Given this list of marker genes CXCL11, TRIM31, PELI1, IFIH1, USPL1 (NCBI Gene Id 10208), SLC31A2, HMGN2P46, NACA2, APOBEC3A, H1-6, SYNPR, ARHGAP27, DNAJB5, MYEF2, NR4A3, DNAJC27, RAB11FIP1, CLK4, EPSTI1, SWT1, TENT4A, BPIFA2, PGAP1, GTPBP2, GFOD1 (NCBI Gene Id 96191), SPATA18, PARP6, C1GALT1, PARP14, ADAR, WDR33, OASL (2'-5'-oligoadenylate synthetase like), PATL2, SAMD9, SAP30L-AS1, LINC03007, ADM, IRF7, RNF213, GADD45B, S100A7, HESX1, DAND5, C2orf15 (NCBI Gene Id 150590), UNC93B1, UGT2B15, DHX58, TENT5A, BATF2, IFIT2, TMEM212, CCDC57, MYO10, FBXO34, PATL1, ANKS1B, PLA1A, TLK2, DENND2C, B3GAT2, IFI44, IFIT3, PMAIP1 (NCBI Gene Id 9305), FUT4, CATSPERE, TRIM21, RIGI, IRF1, DTX3L, ZBP1, PML, CLK1 (CDC like kinase 1), SPC24, ZNFX1, SRC, SCN11A, DDIT4, IFIT1, IFI35, SIRPG, STAT2, DOP1A, ARID3A, DRC3, ZBTB43, NAMPT, SLC25A28, TGIF1, MASTL, KIF2A, MX1, REC8, HSPA4L, RNF43, HOMER1, MX2, PARP9, KDM6B, MT2A, TRIM25, SORBS3, B4GALT5, SLC1A6, DCP1A, TRIM56, GCH1, CD274, ISG15, DUSP15, C3orf36, PNPT1, CREB5, DIPK1B, PPM1K, SAMD9L, IFI6, UTY, SNAPC1, USP42, C3orf38, NLRC5, RLF, TTC9B, PROC, CCL8, ARL5B, ERRFI1, XAF1, MVB12A, CD80, PHF11, SETD4, PRX, IFI44L, ZNF687, IRAK2, INKA1, RTP4, MAK, NINJ1, THAP3, TRAF1, DDX60, RICTOR, IFIT5, TMEM217, CARINH, LCAL1, IL36A (NCBI Gene Id 83004), HERC6, PAPOLG, RASAL1, PELO, KPNA5, NDC80, ISG20, TNNT1 (troponin T1, slow skeletal type), TAP1, MYADM, MFN1, PLSCR1, LINC02537, SHFL, OAS3, CXCL10, PPP3CC, SNORD89, DDX60L, FNBP4, NT5C3A, APOL1, IFITM1, USP18, HERC5, SP140L, DUSP5, OAS2, MIS18BP1, RSAD2, NR2E1, HELZ2, CMPK2, TAMALIN, TNFSF10, CSRNP1, NFKB2, ZNF107, ARHGAP8, here is a description of the gene set: Genes down-regulated in comparison of control conventional dendritic cells (cDC) at 0 h versus cDCs infected with Newcastle disease virus (NDV) at 4 h. from publication Zaslavsky E, Hershberg U, Seto J, Pham AM, Marquez S, Duke JL, Wetmur JG, Tenoever BR, Sealfon SC, Kleinstein SH (PMID 20164420) Human Gene Set: GSE18791_CTRL_VS_NEWCASTLE_VIRUS_DC_4H_DN The dendritic cell (DC) is a master regulator of immune responses. Pathogenic viruses subvert normal immune function in DCs through the expression of immune antagonists. Understanding how these antagonists interact with the host immune system requires knowledge of the underlying genetic regulatory network that operates during an uninhibited antiviral response. In order to isolate and identify this network, we studied DCs infected with Newcastle Disease Virus (NDV), which is able to stimulate innate immunity and DC maturation through activation of RIG-I signaling, but lacks the ability to evade the human interferon response. To analyze this experimental model, we developed a new approach integrating genome-wide expression kinetics and time-dependent promoter analysis. We found that the genetic program underlying the antiviral cell state transition during the first 18-hours post-infection could be explained by a single regulatory network. Gene expression changes were driven by a step-wise multi-factor cascading control mechanism, where the specific transcription factors controlling expression changed over time. Within this network, most individual genes are regulated by multiple factors, indicating robustness against virus-encoded immune evasion genes. In addition to effectively recapitulating current biological knowledge, we predicted, and validated experimentally, antiviral roles for several novel transcription factors. More generally, our results show how a genetic program can be temporally controlled through a single regulatory network to achieve the large-scale genetic reprogramming characteristic of cell state transitions. species: Homo sapiens